Given this list of marker genes TRIP11, RPS19 (NCBI Gene Id 8378), TP63, POC1A, FANCL, ROR2, here is a description of the gene set: species: Homo sapiens A developmental defect characterized by undergrowth of the sacrum, which is a large, triangular bone at the base of the spine that forms by the fusing of the sacral vertebrae (S1-S5). Human Gene Set: HP_HYPOPLASTIC_SACRUM Hypoplastic sacrum